The following is a description of a gene set: Sodium:potassium-exchanging ATPases are tetrameric proteins, consisting of two large alpha subunits and two smaller beta subunits. The alpha subunits bear the active site and penetrate the membrane, while the beta subunits carry oligosaccharide groups and face the cell exterior. Mouse Gene Set: GOCC_SODIUM_POTASSIUM_EXCHANGING_ATPASE_COMPLEX studied in species Mus musculus, and this is the list of marker genes: Atp1b4, Atp1b2, Atp4b, Atp1b1, Fxyd4, Atp1a1, Atp1b3, Fxyd2, Fxyd1, Atp1a4, Atp1a2, Atp1a3